Given this list of marker genes Ppt1, Syndig1, Itpr2, Ap1g2, Snap29, Atp6v0a4, Wfs1 (NCBI Gene Id 22393), Unc13a, Abcc8, Srebf1, Slc18a3, Syn2, Prrt2, Sec24c, Ap1b1, Sytl4, Doc2a, Lamp5, Tmem184a, Sec23ip, Apc, Lin7c, Phf24, Rab5a, Svop, Tmem163, Atp6v1f, Itpr3, Znrf1, Oprd1, Gria2, Dlg2, Stx1a, Synrg, Sema4c, Gpr151, Ece2 (NCBI Gene Id 66275), Ap1s2, Tafa4, Atp6v0c, Clba1, Sypl2, Slc17a7, Bcl2l1 (NCBI Gene Id 12048), Atp6v0e2, Rab3c, Rab11b, Clta, Rab3a, Syt8, Septin8, Prkn, Nrgn, Vamp3 (vesicle-associated membrane protein 3), Ap1m1, Sec31b, Atp6v1a, Rab11fip5, Phaf1, Atp6v1g3, Srebf2, Atp6v1d, Atp6ap1, Syt13, Sv2b (synaptic vesicle glycoprotein 2b), Cltb, Pef1, Unc13b, Slc35f1, Slc17a8, Slc18b1, Slc17a5, Atp8a1 (NCBI Gene Id 11980), Grin2b, Rph3al, Tprg1l, Slc9b2, Slc32a1, Slc30a2, Vti1b, Syngr4, Lrrk2, Arpc2, Kif1b, Snapin, Pam, Dbh, Synpr, Syngr1, Ptprs, Dmd, Grin1, Slc6a2, Abca12, Bin1 (bridging integrator 1), Slc4a8, Stx6 (NCBI Gene Id 98448), Atp6v1h, Gria1, Vma21, Slc2a3, Stx17, Rab2a, Rab4b, Slc17a6, Syt9, Rab5b, Calm3 (NCBI Gene Id 97428), Tmed10, Atp6v0d1, Sec13, Calm2, Calm1, Pi4k2a, Syt7, Ptprn, Sv2c, Vamp2, Sorl1, Atr (NCBI Gene Id 382093), Rab26, Slc18a2, Gabra2, Dnm1l, Rab5c, Syt11, Sh3gl2, Ica1, Ptprn2, Lin7b, Prrt1, Cltc, Cbarp, Gosr2, Slc35g2, Sec16a, Rph3a, Dtnbp1, Scg3, Slc22a2, Unc13c, Rab10, Cideb, Slc35d3, Pdcd6, Clcn3, Mff, Syt3, Sv2a, Itpr1, Uso1, Slc6a7, Anp32e, Rassf9 (NCBI Gene Id 260311), Mctp2, Atp6v1c1, Mal2, Syn3, Sar1a, Btbd8, Slc6a17, Syt6, Eef1ece2, Anxa5, Slc18a1, Ap1m2, Syt1, Sec23b, Stx7, Snca, Atp6v1g1, Rab3b, Scamp1, Slc17a9, Scamp5, Gad2, Ap4b1, Syt12, Klhl12, Dlg1, Cplx3, Sypl1, Slc6a9 (NCBI Gene Id 14664), Atp6v1b1, Syngr3, Syp, Slc30a5, Dgki, Sar1b, Borcs5, Atp2b1, Scap, Syngr2, Amph, Scgn, Stx16, Dmxl2, Rac1, Vamp1, Aftph, Syt5, Dmbt1, Sec24a, Atm, Slc5a7, Sec16b, Furin, Atp6ap2, Mctp1, Rab27b, Ap1s3, Slc30a8, Car4, Atp6v0a1, Dnajc5, Syn1, Map6, Spred2, Trpm7, Ap1s1, Tmem30a, Vti1a (NCBI Gene Id 70938, vesicle transport through interaction with t-SNAREs 1A), Atp6v1e1, Otof, Syt10, Slc30a3, Rab35, Sec23a (NCBI Gene Id 217612), Rab14, Lamp1, Cpe, Oprk1, Sec31a, Rab7 (RAB7, member RAS oncogene family), Slc10a4, Sec22b, Ap1g1, Lin7a, Stx12, Syt2 (synaptotagmin II), Arfgef3, Sec24d, Atp6v1g2, Atp6v1b2, Rab4a, Drd2, Sgta, Sntb2, Sec24b, Doc2b, here is a description of the gene set: Mouse Gene Set: GOCC_TRANSPORT_VESICLE_MEMBRANE The lipid bilayer surrounding a transport vesicle. studied in species Mus musculus